The following is a description of a gene set: The series of molecular signals initiated by interleukin-23 binding to its receptor on the surface of a target cell, and ending with the regulation of a downstream cellular process, e.g. transcription. studied in species Homo sapiens Human Gene Set: GOBP_INTERLEUKIN_23_MEDIATED_SIGNALING_PATHWAY, and this is the list of marker genes: STAT3, JAK2, IL12RB1, TYK2, IL23R, P4HB